Given this list of marker genes GJD3, GJB5, GJB1, GJC1, GJA1, GJB6, GJB7, PANX2, GJB2, GJA5, GJA8, GJA10, GJE1, GJA4, GJA3, PANX3, PANX1, GJC3, GJB3, GJD4, GJB4, GJC2, GJA9, GJD2, here is a description of the gene set: species: Homo sapiens A wide pore channel activity that enables a direct cytoplasmic connection from one cell to an adjacent cell. The gap junction can pass large solutes as well as electrical signals between cells. Gap junctions consist of two gap junction hemi-channels, or connexons, one contributed by each membrane through which the gap junction passes. Human Gene Set: GOMF_GAP_JUNCTION_CHANNEL_ACTIVITY